Given this list of marker genes secA2, RAB5A, Rv1410c, ptpA, NOS2, RPS27A, esxG, UBB, ATP6V1H, PPE2, VPS33B, sapM, RAB7A, KPNB1, UBA52, CORO1A, lpdC, lprG, UBC, esxH, ndkA, KPNA1, HGS, here is a description of the gene set: Reactome Pathway: Suppression of phagosomal maturation The fate of phagosomes is usually directed by factors in the host phagocyte and involves flooding itself with superoxide, nitric oxide, and protons. Acidification is the prerequisite for later fusion with a lysosome. Mycobacterium tuberculosis (Mtb) releases substances that inhibit all of these processes, effectively arresting the phagosome in the present state and creating a protected niche for Mtb multiplication. part of: Response of Mtb to phagocytosis species: Homo sapiens